The following is a description of a gene set: Mouse Gene Set: chr5A2 studied in species Mus musculus, and this is the list of marker genes: Speer4cos, Gm21190, Speer4c2, Gm21083, Gm43391, Speer4d, Speer4c1, Gm43000 (NCBI Gene Id 115490168), Cacna2d1, Gm21149, Gm21847, Gm3510, 4930519H02Rik, Speer4e2, Gm30613, Speer4e1, Gm17019, Gm9758